The following is a description of a gene set: A process that is carried out at the cellular level which results in the assembly, arrangement of constituent parts, or disassembly of a presynapse. Mouse Gene Set: GOBP_PRESYNAPSE_ORGANIZATION species: Mus musculus, and this is the list of marker genes: Il1rap, Pfn2, Nrg1, Picalm, Lrp4, Pcdh17, Tln2, Lrrc4b, Slitrk1, Efnb1, Dkk1, Farp1, Bsn, Wnt3a, Slitrk3, Ntrk3, C5ar1, Ntng2, Nlgn3, Fzd5, Gpc4, Efnb2, Clstn3, Wnt7a, Snca, Clasp2 (NCBI Gene Id 97514), Arhgef7, Cbln1, App, Efnb3, Slitrk2, Cacna2d3, Dvl1, Nlgn4l, Lrfn5, Grid2, Lrrtm1, Daam1, Nrxn1, Sdcbp, Lrfn3, Nlgn1, Cntn5, Ptprd, Vps35 (NCBI Gene Id 65114), Igsf11, Mdga1 (MAM domain containing glycosylphosphatidylinositol anchor 1), Nlgn2, Ptprs, Pclo, Arf6, Mdga2, Lrrtm3, Pls3 (plastin 3 (T-isoform)), Chd4, Il1rapl2, Snapin, Il1rapl1, Lrfn4, Snap91, Fzd1, Eif4g1, Cap2, Cadm1, Pten